The following is a description of a gene set: species: Homo sapiens The immune system is a complex network of the biological processes that provide defense mechanisms during infection or in response to an intrinsic danger signal. Compromised immune response may present itself as either overactivity or underactivity of the immune system leading to a broad spectrum of clinical phenotypes that can be categorized into four main groups - autoimmunity, immunodeficiency (ID) with a greater susceptibility to infectious diseases, hypersensitivity to compounds that are usually not harmful, and malignancy. Several host conditions may cause dysfunctional immunity. Among them are inherited and somatic mutations found in the components of immune signaling pathways. In addition to genetic defects, infection with pathogens such as human immunodeficiency virus (HIV), or interaction of immune cells with immunosuppressive drugs result in non-genetic immunodeficiencies. Reactome Pathway: Diseases of Immune System part of: Disease, and this is the list of marker genes: TLR4, UNC93B1, CHUK, TLR5, TLR1, FGA, porB, NFKBIA, TLR2, KLKB1, S100A1, IKBKB, TLR3, mip, APP, TIRAP, IRAK4, FGB, S100A8, NFKB1, F2, BTK, TRAF3, MYD88, NFKB2, CD14, CD36, fliC, TLR6, S100A9, TICAM1, F12, FGG, SERPING1, TLR10, LY96, HMGB1, RELA, TLR7, IKBKG (NCBI Gene Id 8517)